Given this list of marker genes PTPRE, CAPS2, ARID2, E2F7, MCUR1, NPAT, NCKAP1, TRIM37, WNT16, RMND5A, CSPG5, MGA, SLC13A3, MINDY2, TRIM9, C10orf71, MALL, ZSCAN2, NR3C1, PRKAG1, PCNX1, NXPH1, CAMK2D, STRN3, LSM11 (LSM11, U7 small nuclear RNA associated), PPP6R2, MSL2, OTX2, RNF141, CCDC3, CAPNS2, PPM1E, HCAR1, TNFSF12-TNFSF13, RAD54B, DIO1, PERP, FSBP, AKR1B15, HNRNPH2, ADSS2, CD28, CTNNAL1 (catenin alpha like 1), MEGF10, DTHD1, BRCC3, UBE2R2, KLHDC10, MOB3B, TNFSF13, STRAP, SPP2 (NCBI Gene Id 6694), TENT4B, AKR1B10, YOD1, IRF1, MTMR6 (myotubularin related protein 6), RPL36A-HNRNPH2, FOS, TBC1D1, NGLY1, KANK2, SRSF2, COA5, RBBP9, ANKRD11, SLITRK4, HAVCR1, PRDX3, RASSF8, RPS6KC1, GAS2L3, TBCK, HYCC2, DZIP1L, MAL2, RBMS1, EPG5, SLC35D2, here is a description of the gene set: from publication Chen Y, Wang X (PMID 31504780) Human Gene Set: MIR383_5P Genes predicted to be targets of miRBase v22 microRNA hsa-miR-383-5p in miRDB v6.0 with MirTarget v4 prediction scores > 80 (high confidence targets). studied in species Homo sapiens